The following is a description of a gene set: part of: Tandem pore domain potassium channels This event has been computationally inferred from an event that has been demonstrated in another species.<p>The inference is based on the homology mapping from PANTHER. Briefly, reactions for which all involved PhysicalEntities (in input, output and catalyst) have a mapped orthologue/paralogue (for complexes at least 75% of components must have a mapping) are inferred to the other species. species: Mus musculus Reactome Pathway: TWIK-related alkaline pH activated K+ channel (TALK) electronically inferred by orthology from the curated human pathway, and this is the list of marker genes: Kcnk16